Given this list of marker genes Idh3g, Ogdh, Kat2a, Mrps36, Ogdhl, Abhd11, Bckdhb, Idh3a, Sucla2, Bckdk, Idh3b, Bckdha, Dlst, Suclg2, Dld, Suclg1, here is a description of the gene set: Mouse Gene Set: GOCC_TRICARBOXYLIC_ACID_CYCLE_HETEROMERIC_ENZYME_COMPLEX Any of the heteromeric enzymes that act in the TCA cycle. species: Mus musculus